Given this list of marker genes Dld, Timm8b, Idh1, Aco2, Etfa, Aldh6a1, Pdhb, Hsd17b10, Sdhb, Atp5mc1 (ATP synthase membrane subunit c locus 1), Cox6a1, Ndufs1, Got2, Maob, Rhot2, Uqcrc2, Glud1, Ndufv1, Timm9, Cox4i1, Ndufv2, Ndufb6, Ndufa3, Pdhx, Cyc1, Pmpca, Ndufs7, Mrps12, Mrpl15, Acat1, Atp6v1h, Atp6v1e1, Cyb5a, Pdk4, Sdha, Gpi1, Polr2f, Mdh1, Ogdh, Gpx4, Ndufa2, Por, Mrpl35, Atp5f1e, Cpt1a, Cox11, Htra2, Hspa9 (heat shock protein 9), Mrps30 (mitochondrial ribosomal protein S30), Acadm, Cox7a2l, Etfb, Mtrr, Timm13, Bckdha, Idh3a, Idh2, Atp5pb, Atp6v0b, Ndufb3, Rhot1, Atp5mc3, Atp5po, Acaa1a, Fdx1, Ldhb, Timm17a, Mrpl34, Atp1b1 (ATPase, Na+/K+ transporting, beta 1 polypeptide), Hadha, Surf1, Eci1, Etfdh, Pdha1, Hccs, Mrps22, Uqcrh, Sucla2, Nqo2, Slc25a20, Mrps11, Ndufs8, Ndufs3 (NADH:ubiquinone oxidoreductase core subunit S3), Atp5mf, Cox7c, Acadvl, Atp5f1c, Ndufa1, Ndufa7, Cox6b1, Atp5f1b, AK157302, Atp6v0c, Atp6v1g1, Hadhb, Ndufa4, Ndufs2, Ndufa8, Cox6c (NCBI Gene Id 12864), Atp6v1c1, Atp5pf, Uqcrc1, Fxn, Atp6v0e, Ndufa6, Cox7b, Ndufa9, Cox8a, Uqcrb, Ldha, Iscu (NCBI Gene Id 66383), Atp5f1a, Alas1, Fh1, Mpc1, Aifm1, Idh3b, Phb2, Atp6v1f, Mtrf1, Mtx2, Atp6ap1, Bdh2, Ndufc2, Vdac2, Mfn2, Decr1, Atp6v1d, Slc25a3, Vdac3, Tomm22, Mrpl11, Ndufb7, Cox17 (NCBI Gene Id 12856), Bax, Cox15, Casp7, Idh3g, Cox5a, Ndufs4, Phyh, Dlst, Nnt, Ndufs6, Opa1 (NCBI Gene Id 74143), Acadsb, Sdhc, Ndufab1 (NCBI Gene Id 72270), Oxa1l, Afg3l2, Uqcr11, Cox10, Timm50, Ndufb8, Ndufb2, Acaa2, Retsat, Echs1, Lrpprc, Mdh2, Slc25a11, Slc25a5, Dlat, Oat, Abcb7, Sdhd, Prdx3, Tomm70a, Cyb5r3, Ech1, Cs, Mgst3, Timm10, Atp5f1d, Supv3l1, Pdp1, Grpel1, Vdac1, Ndufa5, Cox5b, Ndufc1, Ndufb5, Uqcrq, Tcirg1, Cox7a2, Atp5pd, Suclg1, Gm10053, Uqcr10, Uqcrfs1, Atp5me, Slc25a12, Slc25a4, Mrps15, Immt (inner membrane protein, mitochondrial), here is a description of the gene set: species: Mus musculus from publication Howe DG, Blake JA, Bradford YM, Bult CJ, Calvi BR, Engel SR, Kadin JA, Kaufman TC, Kishore R, Laulederkind SJF, Lewis SE, Moxon SAT, Richardson JE, Smith C (PMID 30224793) Mouse Gene Set: HALLMARK_OXIDATIVE_PHOSPHORYLATION Mouse genes annotated to HALLMARK_OXIDATIVE_PHOSPHORYLATION based on orthology mappings provided by the Alliance Genome Consortium